The following is a description of a gene set: studied in species Homo sapiens A stage in the circadian sleep cycle during which dreams occur and the body undergoes marked changes including rapid eye movement, loss of reflexes, and increased pulse rate and brain activity. Human Gene Set: GOBP_CIRCADIAN_SLEEP_WAKE_CYCLE_REM_SLEEP, and this is the list of marker genes: CRH (corticotropin releasing hormone), CHRNB2, GHRH, GABRB3, GHRL